The following is a description of a gene set: Generalized ichthyosis species: Homo sapiens Human Gene Set: HP_GENERALIZED_ICHTHYOSIS, and this is the list of marker genes: PHGDH, PNPLA1, SLC27A4, NIPAL4, LORICRIN